Given this list of marker genes ATL1, WNK1, RETREG1, GJB2, NTRK1 (neurotrophic receptor tyrosine kinase 1), KIF1A, SCN9A, TRPV3, VPS33B, TREX1, SPTLC2, TGM1, KRT1 (keratin 1), MPV17, here is a description of the gene set: Autoamputation of digits studied in species Homo sapiens Human Gene Set: HP_AUTOAMPUTATION_OF_DIGITS The spontaneous detachment of a digit (finger or toe) from the body due to long standing pathology.